Given this list of marker genes GNPTAB, NR1H3, NR1H2, M6PR, BLOC1S3, NAGPA, BLOC1S6, here is a description of the gene set: The controlled release of lysosomal enzymes by a cell. species: Homo sapiens Human Gene Set: GOBP_SECRETION_OF_LYSOSOMAL_ENZYMES